Given this list of marker genes 1700021P04Rik, Apba1, Ostf1, C330002G04Rik, Smc5, Gm32750, Cfap95, Fxn, Gm18610, Gm25437, Klf9, Gm6563, Dmrt3, Anxa1, Gm22684, Gm41815, Pip5k1b, Gm27151, Gm6684, Trpm6, Prune2, Nmrk1, Mir1192 (NCBI Gene Id 100316672), Tjp2 (NCBI Gene Id 226034), Zng1, Eef1a1-ps1, Gm9493, Mamdc2, Gm5249, Gm3728, Gm41821, Rorb (NCBI Gene Id 225998), Aldh1a7, Pgm5, 1500015L24Rik, Nsa2-ps1, Kank1 (KN motif and ankyrin repeat domains 1), Pcsk5, Rfk, Gda, Tmem252, Gcnt1, Vps13a, 1110059E24Rik, D030056L22Rik, Zfand5, Gm22880, Cemip2, Gm21542, Carnmt1, Gm22506, Gm50212, Mir204, Entrep1, Gm3443, Gm50341, Gm23238, C730002L08Rik, Tmc1, Gm32256, Gm26207, 4930554I06Rik, Pabir1, Ptar1, Foxd4, Gm17819, Gm17800, Gm22144, Ldhb-ps, Trpm3 (NCBI Gene Id 435591), Gm8250, Gm41819, Gm34432, Foxb2, Gm10053, Pip5k1bos, Gm32629, Gm32341, Dock8, Gm24252, Abhd17b, Dmrt1, Aldh1a1, here is a description of the gene set: Mouse Gene Set: chr19B species: Mus musculus